Given this list of marker genes Rps6ka6, Etv2, Pus7, Cer1, Mixl1, Sall1, Trp63, here is a description of the gene set: Mouse Gene Set: GOBP_REGULATION_OF_MESODERM_DEVELOPMENT species: Mus musculus Any process that modulates the frequency, rate or extent of mesoderm development.